Given this list of marker genes CLCN7, TBCD, SQSTM1, MTAP, TNFRSF11A, here is a description of the gene set: species: Homo sapiens Human Gene Set: HP_RECURRENT_LONG_BONE_FRACTURES An increased tendency to fractures of the long bones (Mainly, the femur, tibia, fibula, humerus, radius, and ulna). Recurrent long bone fractures